Given this list of marker genes Scd1, Alb, S100a3, Cox6a2, Pcdh12, Tnnc2, Cfd, Ckm, Tnnt3, Igfbp5, Myh2, Plxnb2, Actn3, Mylpf, Atp2a1, Myh4 (myosin, heavy polypeptide 4, skeletal muscle), Myh8, Myh1, Tnni2, Aff1, here is a description of the gene set: from publication Hummerich L, Müller R, Hess J, Kokocinski F, Hahn M, Fürstenberger G, Mauch C, Lichter P, Angel P (PMID 16247483) Mouse Gene Set: HUMMERICH_BENIGN_SKIN_TUMOR_DN species: Mus musculus Chemically induced mouse skin carcinogenesis represents the most extensively utilized animal model to unravel the multistage nature of tumour development and to design novel therapeutic concepts of human epithelial neoplasia. We combined this tumour model with comprehensive gene expression analysis and could identify a large set of novel tumour-associated genes that have not been associated with epithelial skin cancer development yet. Expression data of selected genes were confirmed by semiquantitative and quantitative RT-PCR as well as in situ hybridization and immunofluorescence analysis on mouse tumour sections. Enhanced expression of genes identified in our screen was also demonstrated in mouse keratinocyte cell lines that form tumours in vivo. Self-organizing map clustering was performed to identify different kinetics of gene expression and coregulation during skin cancer progression. Detailed analysis of differential expressed genes according to their functional annotation confirmed the involvement of several biological processes, such as regulation of cell cycle, apoptosis, extracellular proteolysis and cell adhesion, during skin malignancy. Finally, we detected high transcript levels of ANXA1, LCN2 and S100A8 as well as reduced levels for NDR2 protein in human skin tumour specimens demonstrating that tumour-associated genes identified in the chemically induced tumour model might be of great relevance for the understanding of human epithelial malignancies as well. Genes down-regulated in benign skin tumors (papilloma) induced by treatment with DMBA and TPA chemicals in the two stage skin carcinogenesis model.